The following is a description of a gene set: studied in species Mus musculus The biological process whose specific outcome is the progression of a lung saccule from an initial condition to its mature state. The lung saccule is the primitive gas exchange portion of the lung composed of type I and type II cells. Mouse Gene Set: GOBP_LUNG_SACCULE_DEVELOPMENT, and this is the list of marker genes: Asxl1, Ltbp3, Fgfr3, Creb1, Tnrc6c, Ptges3, Fgf10, Fgfr4, Foxa1, Gata6, Nkx2-1, Fosl2, Stra6, Sfta3-ps